Given this list of marker genes POU2AF1, CDH17, ADA, IRF8, PHF14, ITFG2, IL21, IL6, SPI1, here is a description of the gene set: species: Homo sapiens The process in which a B cell in the spleen acquires the specialized features of a germinal center B cell. Germinal center B cells are rapidly cycling B cells which have downregulated IgD expression and exhibit high levels of binding by peanut agglutinin (PNA). Human Gene Set: GOBP_GERMINAL_CENTER_B_CELL_DIFFERENTIATION